Given this list of marker genes MIR17, MIR377, EPN2, MIR375, ALOX5, SEMA6A, MIR487B, ADAMTS9, MIR329-1, EPN1, KLF2, MIR34B, MIR19A, MIR138-1, ZNF354C, SYNJ2BP, STARD13, MIR34A, THBS1, E2F2, PIK3CB, CREB3L1, MIR30C1, MIR92A1, MIR20A, MIR18A, MIR34C, MIR495, MIR30E, MIR221, here is a description of the gene set: Any process that stops, prevents or reduces the frequency, rate or extent of sprouting angiogenesis. species: Homo sapiens Human Gene Set: GOBP_NEGATIVE_REGULATION_OF_SPROUTING_ANGIOGENESIS